The following is a description of a gene set: from publication D'Cruz LM, Knell J, Fujimoto JK, Goldrath AW (PMID 20154672) Genes up-regulated in double positive thymocytes: wildtype versus TCF3 knockout. We wanted to test the role of mammalian E proteins E2A and HEB in the development of T cells. Using a conditional deletion system in which these proteins are deleted at the DP stage of T cell development, we compared DP thymocytes deficient for E2A, HEB or both to wild-type thymocytes species: Homo sapiens Human Gene Set: GSE19923_WT_VS_E2A_KO_DP_THYMOCYTE_UP, and this is the list of marker genes: TBX3, HAND1, LYSMD2, RSPO1, CX3CR1, BAG2, ITIH2, ECI1, NCF2, PLS3, FAM8A1, EIF2A (eukaryotic translation initiation factor 2A, NCBI Gene Id 83939), NSD1, ZFP1, SYCP1, EMC2, GADD45G, LRIG1, FRZB, TFF2, MTMR7, ACOT2, GFI1, ASGR2, NEFM, FLT1 (fms related receptor tyrosine kinase 1), GSTM3, BOLA3, CFAP184, WDR82, GFRA3, ERO1B (NCBI Gene Id 56605), PTGFR, CETN2 (NCBI Gene Id 812, centrin 2), KLHL21, GLRX3, BCL7B, NES, SFRP2, CCNJ, PITX1, SSPN, TXNIP, MESP2, MED22, LHX6, VAPB, IL9, LAMC2, RPTN, MMP11, RPL14, EFNB2, ZMYM4, MMUT, GADD45B, POLE2, SEC11C, NICN1, CLCN7, UBE2L3, CBLN1, TBCB, CELSR2, SCAND1, KRT14, DMTN, CDH2, KLF17, TRIAP1, MID1, AEBP1, IRF6, HES6, TMEM268, TMEM126A, CKMT2, RPL23, HLX, NIT2, CACHD1, ZC3H14, SPSB1, ERMP1, CYP8B1, ALDH1A3, CXCR2, CFTR, ADGRG3, DMTF1, GRIN2B, ATP5F1A, HFE, FICD, CRP (NCBI Gene Id 1401), DRD3, SNAP25, ANKRD49, GAP43, SERAC1, SERPINB5, RAB3B (NCBI Gene Id 5865), CD44, ANKRD11, ERCC1, CCR5, SLURP1, CDH13, SESN1, ADAMDEC1, AVPI1, CITED1, KLHL9, TENM4, PSMA1, SLC11A2, COPE, SOX15, DAPK3, GDPD5, CYP21A1P, LATS2, AKR1B15, CRY2, RFXANK, CDK5, ZNHIT3, DNPH1, LBP, KRTAP19-5, MAPRE2, TNNC1, PGLYRP1, IKBKG, GUCY2C, HMGA2, OXNAD1, UBE2J2, PCP4, PTGS2, WDR75, ST8SIA1, EID1, PKDCC, TAT, DPH5, TNFRSF19, IL17A, SPCS2, GDI2, PTGIR, CLEC4A, WNT4, TGFB2, TNPO1, UNG, MIIP, CDKN2AIPNL, NDUFB5, IFT70B, ITGA4, F10, NKIRAS1, STEEP1, DDIT4, ADCY8 (adenylate cyclase 8), SEMA4B, ESR2, PSMA7, SMU1, ARFIP2 (NCBI Gene Id 23647), S1PR1, KRT72, IL15, KLF10 (NCBI Gene Id 7071), RO60, DSPP, ALDH3A1, BASP1, RPS8, GABRG1, ABCC2, TEKT2, TNFRSF1A, H2BC18, CKB, COX7A1, CRYL1, C12orf57, CD80, PPP1R7, NDUFA8, EIF4ENIF1, CILP2, PEX2, TMEM129, HOXB7, ACY1, SRP9, PARP2